The following is a description of a gene set: species: Mus musculus Mouse Gene Set: REACTOME_EICOSANOID_LIGAND_BINDING_RECEPTORS Eicosanoid ligand-binding receptors, and this is the list of marker genes: Tbxa2r, Ptger4, Ltb4r2, Ptgfr, Ptgdr2, Ptger1, Ptgdr, Gpr17, Ptger3, Cysltr1, Ltb4r1, Cysltr2, Ptger2, Ptgir